Given this list of marker genes Tnfrsf19, Sfrp5, Wnt16, Mapk8ip2, Naip6, Taok1, Sfrp1, Pja2, Tnxb, Rassf2, Marveld3, Cd27, Gadd45b, Ltbr, Il3, Birc7, Ulk4, Mdfic, Gps2, Fcgr2b, Sh3rf3, Cbs, Tnf, Asb15, Men1, Traf4, Aida, Gadd45g, Ccdc88c, Ccl21b, Phlpp1, Wnt7a, Edn1, Cracr2a, Ager, Hipk2, Naip5, Cops5, Wnt7b, Ephb1, Ripk1, Mturn, Ccl21f, Il1a, Map4k2 (NCBI Gene Id 26412), Hdac3, Zmynd11, Wnt5a, Nod2, Gstp2, Tpd52l1, Hmgb1, Stk3, Mdfic2 (MyoD family inhibitor domain containing 2), Edar, Per1, Tlr4, Map3k1 (mitogen-activated protein kinase kinase kinase 1), App, Mapk8ip3, Map3k11, Nrk, Eda2r, Tgfbr3, Il1b, Akt1, Fktn, Dusp19, Dvl3, Map2k4, Dvl2, Hras, Sh3rf2, Ccl21a, Gadd45a, Prkn, Dusp22, Xiap, Itch, Axin1, Dnaja1, Klhl31, Tirap, Sirpa, Fgd4, Tnik, Nod1, Igf1r, Map2k7, Nppa, Tnfsf11, Ccn2, Dusp10, Mdfi, Pdcd4, Map3k5, Mbip, Dixdc1, Myoc, Pycard, Map4k4, Zfp110, Card9, Mapk8ip1, Lmnb1, Ncor1, Gstp1, Cdc42se1, Mfhas1, Cdc42, Nox1, Zfp622, Traf2, Ccl19-ps5, Dkk1, Myd88, Rb1cc1, Hipk3, Flt4, Ccl19-ps6, Ptk2b, Taok3, Pafah1b1, Trpv4, Ccl19-ps1, Naip2, Ccl19, Serpinf2, Tlr3, F2rl1, Prmt1, Plcb1, Unc5cl, Dab2ip, Ccl21d, Slamf1, Grik2, Mapk9, Dact1, Rapgef1, Naip1, Tlr9, Map3k10, Gstp-ps, Sh3rf1, Gstp3, Ankrd6, Ccl19-ps3, Dab2, Fzd10, Taok2, Mapkbp1, Rnf13, Mink1 (misshapen-like kinase 1 (zebrafish)), Sfrp2, Fgf15, Ccl21e, Egfr, Dusp3, Ccl19-ps4, Sfrp4, Asb3, Rasgrp1, Mecom, Ripk2, Crk, Ptpn22, Cyld, Rap2a, Map3k7, here is a description of the gene set: Mouse Gene Set: GOBP_REGULATION_OF_JNK_CASCADE species: Mus musculus Any process that modulates the frequency, rate or extent of signal transduction mediated by the JNK cascade.